The following is a description of a gene set: species: Homo sapiens Human Gene Set: GSE14308_TH1_VS_INDUCED_TREG_DN Genes down-regulated in comparison of Th1 cells versus induced regulatory T cell (Treg). from publication Wei G, Wei L, Zhu J, Zang C, Hu-Li J, Yao Z, Cui K, Kanno Y, Roh TY, Watford WT, Schones DE, Peng W, Sun HW, Paul WE, O'Shea JJ, Zhao K (PMID 19144320) Multipotential naïve CD4+ T cells differentiate into distinct lineages including T helper 1 (Th1), Th2, Th17, and inducible T regulatory (iTreg) cells. The remarkable diversity of CD4+ T cells begs the question whether the observed changes reflect terminal differentiation with heritable epigenetic modifications or plasticity in T cell responses. We generated genome-wide histone H3 lysine 4 (H3K4) and lysine 27 (H3K27) trimethylation maps in naïve, Th1, Th2, Th17, iTreg, and natural (n)Treg cells. We found that although modifications of signature cytokine genes (Ifng, Il4, and Il17) partially conform to the expectation of lineage commitment, critical transcription factors such as Tbx21 exhibit a broad spectrum of epigenetic states, consistent with our demonstration of T-bet and IFN-gamma induction in nTreg cells. Our data suggest an epigenetic mechanism underlying the specificity and plasticity of effector and regulatory T cells and also provide a framework for understanding complexity of CD4+ T helper cell differentiation., and this is the list of marker genes: USP49, TSPAN11, ASPHD2, MRPL47, ECSIT, PPP6R2, NMT1, RPL19, FDXR, GNB4, BSND, HNRNPAB, CYP1B1, MKRN2, WFS1, KRT4, EHD1, MTMR11, SMPD4, MBD3, DHX32, ATP5MC2, EMC1, ZMYND8, BLNK, CPQ, PES1, CNIH3, CHIC2, RPS8, MRPL23, ZDHHC14, LRRC8D, RUSF1, FSCN1, HSBP1, SGO1, PAMR1, EHBP1, FARSA, NUP58, ERI1, OBP2B, FOXF2, VDAC3, TAF4B, MRPS12, CCNO, NRDE2, LHX2, ADGRL4, DYNLL1, PPIH, LAS1L, RPP25L, MIGA1, ENOPH1, SIGMAR1, RHOG, RRS1, NT5DC3, IBA57, MALSU1, CES5A, KLHDC10, ATP8A2, AMACR, WDR7, LCMT2, MDC1, BTBD6, EIF2B2 (eukaryotic translation initiation factor 2B subunit beta), VHL, SEC11A, THEM6, SEPTIN8, VAX2, MAPK8, NANS, NAA38, SYNDIG1L, ACO1, HYCC1, CFLAR, MAPK1, INF2, CORO1C, SP1, BANK1, ARFIP1, PBDC1, GANAB, SLC35A4, PDGFRL, POMGNT1, VAC14, PDSS2, FBXO6, HIBCH, PSMA2, GDAP1L1, IGF2R, NCAPG2, CCDC61, BCL6B, BUD31, CAPSL, ADI1, ARHGEF4, ARMCX4, GARIN1B, FANCM, PCNX3, CFAP418, MIEN1, STUB1, DUSP12, ADAMTS15, DRP2, RPAIN, C12orf56, MECR, TRIM37, TCAP, RBCK1, COPS3 (NCBI Gene Id 8533), CRTAM, HAUS8, SEC61A2, NASP, BTF3L4, PGAM2, GLRX5 (NCBI Gene Id 51218), CACTIN (NCBI Gene Id 58536), HMGXB4, AP1B1, RNF123, PHACTR4, HJURP, ATF4, BAG1, PPP1R21, PPIP5K1, RBBP4, TMCC3, COX4I1, MCPH1, B4GALT4, SEPTIN9, GLG1, SOX12, GJA10, PIGF, ARC, POMT1, CD38, CCT6A, ACAA1, MORC2, SMYD4, LUZP1, NIPSNAP3A, DANCR, UBQLN1 (NCBI Gene Id 54347), SH2D2A, MED19, ACLY, CIB4, DYNC2I1, AMFR, NAGPA, SKIC8, KLF3, HDAC1, PLAU, YTHDF1, KCTD11, CRYBB2, TRIP6, UBE3B, METTL13, LONP1, LBX1, RIOX1, HNRNPUL1, DDIT4L, PHPT1, NFKBIE, NICN1, LIAS, SETDB2, HSPB7, REXO4, SEM1, OGFOD1, FST, DDX20, OTULIN, ATF6B, RPL10